Given this list of marker genes Zfp146, Dapl1, Zfp748, Elp5, Ifi35, Anapc7, Ifit1, Abcf2, Lss, Tbc1d17, Neurl4, Lztfl1, here is a description of the gene set: from publication Cui A, Huang T, Li S, Ma A, Pérez JL, Sander C, Keskin DB, Wu CJ, Fraenkel E, Hacohen N (PMID 38057668) Cytokines mediate cell-cell communication in the immune system and represent important therapeutic targets. A myriad of studies have highlighted their central role in immune function, yet we lack a global view of the cellular responses of each immune cell type to each cytokine. To address this gap, the authors created the Immune Dictionary, a compendium of single-cell transcriptomic profiles of more than 17 immune cell types in response to each of 86 cytokines (>1,400 cytokine-cell type combinations) in mouse lymph nodes in vivo. A cytokine-centric view of the dictionary revealed that most cytokines induce highly cell-type-specific responses. For example, the inflammatory cytokine interleukin-1β induces distinct gene programmes in almost every cell type. A cell-type-centric view of the dictionary identified more than 66 cytokine-driven cellular polarization states across immune cell types, including previously uncharacterized states such as an interleukin-18-induced polyfunctional natural killer cell state. Mouse Gene Set: CUI_MAST_CELL_IL36A_RESPONSE_UP Genes positively differentially expressed in cell type: Mast cell upon treatment with cytokine: IL-36α in mouse lymph nodes in vivo. studied in species Mus musculus